The following is a description of a gene set: from publication Ji Q, Liu PI, Chen PK, Aoyama C (PMID 15386376) species: Homo sapiens Genes up-regulated in MCV152 cells (ovarian cancer) treated with follicle stimulating hormone (FSH). Human Gene Set: JI_RESPONSE_TO_FSH_UP Epidemiologic data have implicated reproductive follicle-stimulating hormone (FSH) as a probable risk factor for ovarian cancer (OC) development. Although pituitary and sex hormones have been reported to regulate OC cell growth, no information is available on the influence of FSH on gene expression profiles during ovarian surface epithelial (OSE) cell proliferation. This study evaluated the effect of FSH treatment on cell proliferation of various OSE cell lines and gene expression profiles with FSH treatment. Follicle-stimulating hormone receptor (FSHR) was found at higher expression at both transcriptional and protein levels in ovarian cancerous tissues compared to normal tissues, and FSH was shown to promote cell growth in 3 OSE cell lines. Furthermore, it was also found that overexpression of FSHR in Chinese hamster ovary (CHO) cells leads to cell proliferation. Using cDNA MicroArray analysis on MCV152 cells with FSH treatment, genes were found upregulated and genes downregulated for more than 2-fold after FSH treatment. Most of the genes were related to metabolism, cell proliferation and oncogenes. Downregulated genes included tumor suppressor genes (RB1, BRCA1, BS69) and the genes related to cell proliferation control. Pathway analysis found that FSH activates certain important enzymes in sterol biosynthesis pathways. FSH-induced gene expression profiles on MCV152 cells support the standing hypothesis that FSH is a probable risk factor for ovarian cancerous development., and this is the list of marker genes: ATP5ME, GOSR1, PAF1, CFHR1, ME3, FDPS, FDFT1, DPYSL3, H2AC18, SLC4A3, CASP6, ANK3, PIR (NCBI Gene Id 8544), RBP1, SEPTIN6, SLC16A4, AKR1C3, FADS2, CCNG2, CTNNB1, KAT8, ISG15, PDCD4, LAMA4, BFSP1, ACADS, CRYBG1, CLU, NAB1, FASN, CPT1B, PPL, SPOP, COL3A1, CYP51A1 (cytochrome P450 family 51 subfamily A member 1), MVD, PLXNC1, PLAAT4, CASP1, SQLE (NCBI Gene Id 6713), PSMB4, PSMB9, IDI1, CTTN, NT5C2, EBP, MEIS1, TNPO1, TM7SF2, SRSF6, XPC (NCBI Gene Id 7508), BRD3, C1R, BTN3A1, HMGCR, IFI35, FCGRT, H4C3, IL10RB, CBR1, COL16A1, FADS1, HNRNPDL, IFITM1, TRAPPC6A, ZNF148, ERG28, AXL